Given this list of marker genes ICA1, PRSS8, IGFALS, COBL, MPND, SHC4, HAPLN4, MAGEB2, ABCB4, CIDEB, SLC22A1, PYGL, RAPGEF4 (Rap guanine nucleotide exchange factor 4), PTK6, CLDN14, AADACP1, MOGAT3, LAMB3, H2AZ2P1, TUBE1, POLD2, CLDN3, POR, CLDN15, MAP1LC3A, FNDC5, ADSS1, GLCCI1, MAD1L1, TM6SF2, GCK, PRKAG2, PFKFB1, TLE2, SYTL4 (synaptotagmin like 4), PEMT, CHN2, WNK3, CROT, GCGR, CRYAA, TSPAN33, CYP2A7, MNS1, POT1, CHAC1, NLRP11, FBXO2, LRRC31, SLC28A1, AZGP1P2, SLC25A47, TRIM35, FCGRT, SRD5A1 (steroid 5 alpha-reductase 1), TKFC, DHRS1, MFSD2A, MPPED1, PILRB, ADAMTS17, PEPD, ANO1, FOLH1, ARMC6, TMEM139, DAO, ADCY1, GARNL3, HAAO, ZSCAN21, CYP2A6, LINC01018 (NCBI Gene Id 255167), GPR88, EPHA1, ELAVL1, CDHR3, RHOU, SLC16A2, here is a description of the gene set: Hepatocellular carcinomas represent the third leading cause of cancer-related deaths worldwide. The vast majority of cases arise in the context of chronic liver injury due to hepatitis B virus or hepatitis C virus infection. To identify genetic mechanisms of hepatocarcinogenesis, we characterized copy number alterations and gene expression profiles from the same set of tumors associated with hepatitis C virus. Most tumors harbored 1q gain, 8q gain, or 8p loss, with occasional alterations in 13 additional chromosome arms. In addition to amplifications at 11q13 in 6 of 103 tumors, 4 tumors harbored focal gains at 6p21 incorporating vascular endothelial growth factor A (VEGFA). Fluorescence in situ hybridization on an independent validation set of 210 tumors found 6p21 high-level gains in 14 tumors, as well as 2 tumors with 6p21 amplifications. Strikingly, this locus overlapped with copy gains in 4 of 371 lung adenocarcinomas. Overexpression of VEGFA via 6p21 gain in hepatocellular carcinomas suggested a novel, non-cell-autonomous mechanism of oncogene activation. Hierarchical clustering of gene expression among 91 of these tumors identified five classes, including CTNNB1, proliferation, IFN-related, a novel class defined by polysomy of chromosome 7, and an unannotated class. These class labels were further supported by molecular data; mutations in CTNNB1 were enriched in the CTNNB1 class, whereas insulin-like growth factor I receptor and RPS6 phosphorylation were enriched in the proliferation class. The enrichment of signaling pathway alterations in gene expression classes provides insights on hepatocellular carcinoma pathogenesis. Furthermore, the prevalence of VEGFA high-level gains in multiple tumor types suggests indications for clinical trials of antiangiogenic therapies. from publication Chiang DY, Villanueva A, Hoshida Y, Peix J, Newell P, Minguez B, LeBlanc AC, Donovan DJ, Thung SN, Solé M, Tovar V, Alsinet C, Ramos AH, Barretina J, Roayaie S, Schwartz M, Waxman S, Bruix J, Mazzaferro V, Ligon AH, Najfeld V, Friedman SL, Sellers WR, Meyerson M, Llovet JM (PMID 18701503) Marker genes up-regulated in the 'chromosome 7 polysomy' subclass of hepatocellular carcinoma (HCC); characterized by polysomy of chromosome 7 and by a lack of gains of chromosome 8q. Human Gene Set: CHIANG_LIVER_CANCER_SUBCLASS_POLYSOMY7_UP species: Homo sapiens